The following is a description of a gene set: species: Homo sapiens Distance between the hairline (trichion) and the glabella (the most prominent point on the frontal bone above the root of the nose), in the midline, more than two SD above the mean. Alternatively, an apparently increased distance between the hairline and the glabella. High anterior hairline Human Gene Set: HP_HIGH_ANTERIOR_HAIRLINE, and this is the list of marker genes: RALGAPA1, CTBP1, HS2ST1, NELFA, RERE, JARID2, NOVA2, PEX1, CWC27, FLNA (filamin A), KCNH1, NEPRO, ERI1, STAG2, PPP1R13L, EBF3, HEATR3, LMX1B, NSD1, SETD2, KDM1A, UGP2, PPP1CB, ALX3, PIGA, SOS1 (NCBI Gene Id 7838), STT3A, ZC4H2, PIGK, GMPPA, ATP6V1B2, CDH1, CLCN3, ZFX, TWIST1, CCNK, SLC26A2, SMO, CPLX1, ANKRD17, PIGG, LETM1, SLC35C1, SPEN, BICRA, GDF11, DHX30, TBL1XR1, H1-4, MED12, HYOU1, ALX1, IFIH1, PEX6, PRKD1, EFNB1, SYT1, ADARB1, MEIS2 (NCBI Gene Id 56908), SPECC1L, DEAF1, NSD2 (NCBI Gene Id 7468), WNT4, DPH2, LRP2, SIN3A, DLX4, SATB1, FAT4, THOC6, MID1, H4C5, EFEMP1, GNB2, ADNP, SLC9A7, FGD1